The following is a description of a gene set: Pathway Definition from KEGG: (NNK,NNN) -> CHRNA7 -> Ca2+ -> PI3K -> PIP3 -> AKT -> (MTOR,NFKB,BIRC5) species: Homo sapiens Human Gene Set: KEGG_MEDICUS_ENV_FACTOR_NNK_NNN_TO_PI3K_SIGNALING_PATHWAY_N01339 NNK/NNN to PI3K signaling pathway. Pathway ID: N01339. Pathway type: Env factor. Pathway class: nt06214 PI3K signaling., and this is the list of marker genes: NFKB1, PIK3CA, MTOR, RELA, BIRC5, AKT2, AKT1, CHRNA7, PIK3CD, AKT3, PIK3CB